The following is a description of a gene set: Human Gene Set: GOBP_MICROTUBULE_DEPOLYMERIZATION species: Homo sapiens The removal of tubulin heterodimers from one or both ends of a microtubule., and this is the list of marker genes: MAP6D1, CIB1, MAP1S, BBOF1, DIAPH3, KIF2A, NAV3, KIF21A, WDR47, CCSAP, KIF19, KIF14, KIF2C, AURKB, MID1, STMN4, ARHGEF2, GAS2L2, HDAC6, STMN1, MAP1A, KIF24, BMERB1, STMN2, TTBK2 (tau tubulin kinase 2), NCKAP5, SPAST, TRPV4, MID1IP1, KATNB1, TRIM54, CAMSAP2, TAOK1, KIF18A, TPX2, SPECC1L (NCBI Gene Id 8221), APC, STMN3, CCDC88C, SPEF1, KIF2B, KIF18B, HDGFL3, ATXN7, NCKAP5L, CLASP1, CLASP2, FGF13, GAS2L1, CKAP2, MAP1B, CKAP5, APC2